The following is a description of a gene set: Reactome Pathway: Zygotic genome activation (ZGA) part of: Maternal to zygotic transition (MZT) After fertilization the maternal and paternal pronuclei undergo major changes in epigenetic modifications, including demethylation of DNA and changes in methylation and acetylation of histones. At this 1-cell stage in mouse zygotes and possibly in human zygotes, a minor wave of expression from both the female and male genomes occurs, the minor zygotic genome activation (ZGA, also known as embryonic genome activation, EGA).<br>Among the first loci to be transcribed is the DUX4 array of double-homeobox transcription factors. (DUX4 appears to be homologous in structure and function with Dux of mice.) DUX4 binds the promoters of ZGA-expressed genes such as ZSCAN4, DUXA, DUXB, LEUTX, and KDM4E and interacts with the Mediator complex to activate transcription.<br>DUX4 also binds long terminal repeats (LTRs) of thousands of endogenous retroelements, notably the HERVL family of retroelements, and activates bidirectional transcription that can initiate expression of adjacent genes. Interestingly, this transcription of endogenous retroviruses evidently results in production of retrovirus-like particles in the plasma and tissues of human embryos. <br>DUX4 binds HSATII pericentric satellite repeats and initiates bidirectional transcription. The transcripts appear to be required for subsequent formation of chromocenters, large multichromosome conglomerations of heterochromatin.<br>The minor ZGA is followed by the major ZGA at the 2-cell stage in mice and the 8-cell stage in humans. During the major ZGA, chromatin reverts to a more usual configuration, with broad regions of histone H3 trimethyllysine-4 across genes converted to narrow peaks near transcription start sites. Histones H3.1 and H3.2 are also added at this time. studied in species Homo sapiens, and this is the list of marker genes: YAP1, ZSCAN4, TUT4, KDM4E, DPPA4, TEAD4, TPRX1, TPRX2, LEUTX, EP300 (E1A binding protein p300), DUX4, CREBBP, TUT7, TP53, DPPA2, DUXB, DUXA, TPRXL